The following is a description of a gene set: studied in species Homo sapiens Any process that modulates the frequency, rate or extent of programmed cell death, cell death resulting from activation of endogenous cellular processes. Human Gene Set: GOBP_REGULATION_OF_PROGRAMMED_CELL_DEATH, and this is the list of marker genes: PRAMEF7, PTMA, TAF9B, GAL, APOE, ITGB1, ATF4, MIR22, NONO, MAPK8IP1, SNCB, BCAP31, CBS, USP17L21, CTNNB1, PTK2, SPATA2, MIR142, USP17L17, PANO1, BFAR, ING5, INTS1, RBM10, MTNR1B (NCBI Gene Id 4544), PRAMEF13, CORO1A (coronin 1A), TNFRSF1B, TNFSF11, NCKAP1L, EPC2, PRAMEF26, GLS2, MIR200B, GPX4, RYBP, SON, RPS3A, PPP1CA, TXNIP, BBC3, BBS10, UNG, HSH2D, UFM1, WNT1, TWIST1, AATF, MIR19A, VEGFB, UNC5B, POMC (NCBI Gene Id 5443), CD38, UTP11, DLG5, EYA1, BCL3, PDE1A, CCND2, ITPR1, ANKRD1, ADGRG1, TAF9, UBE2Z, KCNB1, SGK3, NR2E1, CD3G, MAGED1, DBH (dopamine beta-hydroxylase), CDK11A, FAM162A, FAP, MIR29B1, USP17L24, TRAP1, DLC1 (DLC1 Rho GTPase activating protein), BTC, BCL2A1, MTDH (NCBI Gene Id 92140), ERP29, AGO4, SIK1, HTR2A, CAPN10, NPY5R, USP17L18, TMF1, ASAH2, BARHL1, PERP, AURKB, ATP7A, XRCC2, CNTF, ZBTB7A, MAG, UMODL1, MIR204, ITGAV, TERT, SNX6, CAMK2A, TOX3, CASP8, CTTN, MGMT, FOXC2, PLA2G1B, CD2AP, SLC7A11, ICAM1, BCL2, FOXB1, PSMD10, HTATIP2, RASA1, SLC39A7, COPS5, RASSF6, MYCNOS, CASP9, NKX3-2, PEPD, THBS1, MAP3K9, RACK1, TXNDC12, CLIP3, IL2RB, HSPB1, MIR182, KITLG, BCL2L1, VNN1, CBLC, MNT, SNCA, PIK3CG, RPS7, MRGBP, SEMA5A, IL27RA, DOCK8, ERBB4, SARM1, PCSK9, NTF4, AIPL1, CERS6, BCL2L14, PHLDA1, MPV17L, MIR132, CHST11 (NCBI Gene Id 55807), NOP53 (NCBI Gene Id 94457), GNRH1, RIPK1, ID3, ARL6IP5 (NCBI Gene Id 10550), HTRA1, KLF11, NQO1, MIR17HG, RBM5, FBXO7, NR4A2, MECP2, NTRK3, HCK (HCK proto-oncogene, Src family tyrosine kinase), PDCD4, VDAC1, TNFSF9, MIEN1, ARL6IP1, RARG, ANXA1, FAIM, PRKRA, ABL1 (NCBI Gene Id 25), TMEM164, MIR101-1, ZNF622, TARDBP, HGF, IL12A, BRMS1, BNIP3L, EEF1E1, PPIF, APBB2, TJP1, AAMDC, IL12B, IL1A, TNFRSF18, HELLS, RB1CC1, RAF1, MAZ, AQP1, ADPRS, PTMS, NRG1, GATA6, JAK3, NF1 (neurofibromin 1), PLAUR, P4HB (prolyl 4-hydroxylase subunit beta), CASP5, CCAR1, DLX1, NEFL, ATP13A2, ITGB3BP, DPP9, MEAF6, CASP2, APIP, SRPK2, AXL, MMP2, DDRGK1, ARF4, GADD45B, SMG9, PPP2R1B, RICTOR, MBTD1, CCNL1, P2RX7, FHL2, SGK1, SKIL, ORMDL3, CD44, BOK, NOD1, PRAMEF2, F2RL1 (F2R like trypsin receptor 1), APP, MERTK, DHRS2, NTSR1, FGFR2, NUAK2, BMP5, BRD8, RASSF2, CYP1B1, BNIP1, ACTL6A, DDIAS, SET (SET nuclear proto-oncogene), SIN3A, KRAS, SCG2, SERPINB13, MAPKAP1 (NCBI Gene Id 79182, MAPK associated protein 1), PTTG1IP, FCMR, HSPA9, ZSWIM2, TEX261, LOX, E2F1, BTG1, FPR2, WNT4, MIR28, STAT1, ZMYND11, MIR26B, S100A8, PDPN, PHLDA3, GHRL, SOCS2, PLEKHN1, PNMA1, GAS1, CAMK1D, HSPA5, KANK2, NKX2-5, TRAF2, PRF1, RXFP2, AKT1, SLIT2, PELI1, JAK2, CIDEC, SMO, CASP3, PINK1, CSNK2A2, NME1, SH3RF2 (SH3 domain containing ring finger 2), UCN, ITPRIP, ETS1, ARMCX5-GPRASP2, RHBDD1, MIR24-1, RNF183, ITGA1, SAV1, HTRA4, LIG4, TNFRSF25, CAMK2D, PRAMEF27, ANP32E (acidic nuclear phosphoprotein 32 family member E), USP17L1, EYA2, ANGPT1, NOD2, NFKB1, PIK3CD, MDM2, ALX3, PRKCH, GATA2, TNFRSF10C, SLC9A1, TMEM196, CTSD, SLC39A10, PPP1R10, TP53, ENSG00000274276, DAPK1, RAD21, MIR21, MIR181C, KDM2B, LAPTM5, NACC2, CITED2, LATS2, TNFAIP8L1, BTG2, DEDD (death effector domain containing), TGFB3, SELENOS, HIPK3, CIAPIN1, POU4F1, CIDEB, BIRC8, HSPB6, FMR1-AS1, PRKAA1, STK40, SAP18, IL6, TFPT, MIR133A1, PHB1, CREB3L1, WT1, PRAMEF1, CDK1, SPDEF, CRLF1, ANG, PHB2, HIF1A, NME2P1, HRAS, GFRAL, PRAMEF6, ST8SIA2, ATP2A2, BAD, NCK2, DKKL1, USP17L7, SEMA3E, USP17L2, LGALS9, TP73, ANGPTL4 (NCBI Gene Id 93954), ZFP36L1, LEP, PIM1, YWHAZ, VPS72, MAEA, MIR200A, PDK4, GRIK2, GRK5, NRBP2, STAT5B, CARD16, BAG4, GRN, JMY, LAMTOR5, BMP7, CASP4, PRR7, FOXE3, CDKN2A, TP53BP2 (tumor protein p53 binding protein 2), PRDM9 (NCBI Gene Id 56979), ERFE, ASNS, PTCRA, AVEN, CDK11B, SIX4, ACIN1, CCND1, HDAC2, DAB2, PDCD1, HTR2B, GRIN2A, BAG1, IL1B, SYVN1, DAPK2, BCL2L13, IL13, KHDRBS1, FFAR4, IRF5, SLC25A4, ACAA2, PCGEM1, CREB3, OLFM1, CDKN1A, NDUFA13, SIAH1, MAP2K5, BIN1, FOXA1, DNM2, UBQLN1, ING1, ATAD3A, NANOS3, HSPG2, MIR222, NKX3-1 (NCBI Gene Id 4824), PROC, MAPK8, ISL1, STXBP1, HERPUD1, MICAL1, PRKD2, PLA2G3, BCL2L10, FNIP1, MTCH2, TMBIM1, SPHK2, CALR, FGB, RPL26, TMIGD1, EPO, USP42, MED1, RBCK1, FZD1, DYRK3, SIRT2, TM7SF3, CDSN, TNFRSF12A, PYCR1, CD274, MDK, PTGIS, ANP32CP, USP15, ZFP36, TP53BP1, NCOA1, CASP12, RPS6KA1, AIFM1, FOXP1, MIR214, TBX20, PLAGL2, MAGEA3, XBP1, HNF1B, TFAP2A, BMPR1B, RNF122, MIR30B, GRAMD4, USP17L3, FOXO1, ATOH1, TMEM161A, FZD3, TLR4, MYO18A, RGL2, CD28, ZNF830 (NCBI Gene Id 91603), PKHD1, TNFRSF6B, EYA3, ALK, ERCC5, PAX8, PDX1, CDK5, IFNB1, BECN1, HSP90AA1, TSPO, TRIM39 (tripartite motif containing 39, NCBI Gene Id 56658), DLL1, MDM4 (MDM4 regulator of p53), RHOA, RIPK2, PDPK1, TNFRSF1A, ANP32B, BIRC6, EMILIN2, TNFAIP8L2, USP36, CCN1, FBXW7, DDAH2, USP17L5, QRICH1, HTT, POR, STIL, FGF10, PRAMEF22 (PRAME family member 22), SFRP1, EMILIN1, BTK, TLE5 (NCBI Gene Id 166), HIP1R, SC5D, PLCG2, RAPGEF2, TEX11, BIRC2, CXCL12, DEDD2, PAK4, FGFR1, RAD9A, TRIM2, SLC40A1, SRSF6, CASP7, YME1L1, PTH, SLC25A1, TMBIM6, ANXA4, PDCD6, PRDX2, RFFL, SGMS1, BCL10, TNF, KCNMA1, TNFSF12, FBH1, HCLS1 (NCBI Gene Id 3059), PTGS2, PRAMEF4, PRAME, UBB, MAEL, ADAR, EN2, SRPX, PIM2, NFATC4, EDN1, IGF2R, DNAJA3, TBX3, ADORA1, PIK3R1, LRP8, IKBKG, SOX8, FTH1, KRT18, FLNA, INHBA, SH3RF1, ADIPOQ, AKT1S1, FRZB, KIT, KAT2B, CARD6, BLID, ZC3H8, HIPK2, EGLN2, MAPK8IP2, BCL2L11, NPPC, ZNF304, FGF2 (NCBI Gene Id 2247), PLK5, AKR1A1, STK26, BCLAF1, HSPB2, IGF1R, HSP90B1, CRYAB, SLC25A5, USP17L11, NNT, PRAMEF20, HDAC3, KNG1, PPEF2, CAST, CEBPB, PAK5, PA2G4, GSDME, PYCARD, MIR103A1, SHH, DUSP6, MYC, KHDC3L, GBE1, MIR15B, RPL10, KPNA1, TIGAR, MIR495, BIRC7, CD74, SLC25A6, CXCL10, NSMF, BABAM2, NTRK1, INHBB, ADCY10, PRELID1, MARCHF7, RAG1, RORC, STK17A, TRRAP, SLC46A2, BID, NAE1, FASLG, ATAD5, KIF14, GBA1, AZU1, UBD, UNC5C, TFAP4, STPG1, TFRC, AKR1C3, KAT5, ACTC1, SERPINB2, PDIA3, STK3, NOS1, IVNS1ABP, UCP2, USP17L20, GPAM, GIMAP8, CBL, XIAP (X-linked inhibitor of apoptosis), MPO, ERBB2, HMGA2, TREM2, HOXA13, DAB2IP, MIR34A, CAPN2, RRM2B, MIR375, SCRT2, RARB, API5 (apoptosis inhibitor 5), SFRP4, YAP1, SNAI1, EEF2K, SLC25A27, ARAF, TRIM24, S100B, PPP2R1A, PDCD5, TIA1, PLXND1 (NCBI Gene Id 23652), SLC25A31, MCL1, NOTCH2, CASP14, MAGEA4 (NCBI Gene Id 4103), TSC22D3, PITX3, STK4, BEX2, CARD10, RUVBL2, OXR1, STUB1, SQSTM1, WNT7A, RNF144B, ATG5, FGF20, DCUN1D3, MIR30E, CCL5, NGF, USP17L6P, ZBTB16, COL2A1, PARK7, MIR186, CLCF1, CEACAM5, TSC22D1, PF4, BDKRB2, TYRO3, MAP3K11, PRAMEF8, CTNNBL1, DDR2, DEPTOR, NRP1, FXN, WNT10B, FYN, EP400, IDO1, TOMM70, ENO1, MIR4516, RTKN, BAX, MSX2, PLCG1, GDF5, ITM2C, POU3F4, WNT16, RRN3 (RRN3 homolog, RNA polymerase I transcription factor), TSLP, TRAF5, EIF2AK2, CDK19, IP6K2, NOS3, FRS2, YBX3, VEGFA, ACSL5, CAT, CRADD, PRLR, SIRT4, ACER2, ARMC10, GLI3, CARD8, PDCD2, LPAR1, CDKN2D, EIF2AK3, UNC13B, TPT1, PIM3, CD248, CCR7, TMBIM4, EVI2B, HDAC1, WNT5A, MIR451A, COMP, GATA4, XPNPEP1, MIR125A, FAS, AHI1, ECT2, GLO1, TRAF7, MAP3K5, MIR98, PCGF2, ADAM8, TENT5B, GHSR, BAG3, EPC1, DIPK2A, LILRB1, PSMG2, NAA35, PRAMEF5, GDNF, CALHM2, MAP3K20, CLU, USP17L19, CLEC5A, ATF5, GCG, MET, BACE1, BARD1, NUP62, ARHGEF2, GPX1, DUSP1, ACVR1, ANP32A, RNPS1, CASP1, LMNA, STYXL1, LCN2 (NCBI Gene Id 3934), ACER3, NAA38, BMF, DRAXIN, URI1, FADD, PRODH, ATM, REST, LIMS2, BDNF, MIR27B, HSPD1, SOCS3, RNF31, CTSH, YEATS4, MIR212, DNAJC3, FATE1, PTPA, RETREG1, PTRH2, MAP3K10, WNK3, CCNL2, BCL2L2, CEACAM6 (CEA cell adhesion molecule 6), LGALS3 (NCBI Gene Id 81625), GHITM, LATS1, TGFB1, TNIP2, ITGB3, PPT1, SLK, ARHGEF7, SERINC3, FOXL2, ALPK2, EEF1A2, LYN, TXNDC5, DNAJC5, ADNP, ACLY, BCL2L15, ELL3, KDM1A, NEUROD1, GRID2 (NCBI Gene Id 2895), CSRNP3, PAK2, TRAF6, PPID, EI24, PELI3, FCER1G, IL31RA, NACA, MIR361, MARK4, HMOX1, TRADD, ASAH1, CX3CR1, NFE2L2, PAX7, CCL2, C1QBP, SPRY2, BAG5, PPARG, NAIP, HIGD2A, SMAD3, BIRC3, LRP2, SLC1A1 (solute carrier family 1 member 1), TFAP2B, HMGN5, ACTN3, MIR29A, USP17L13, KDR, TNFRSF10D, FKBP8, AMIGO2, MIR195, ANGPT4, ADA (adenosine deaminase), LTK, GPRASP3, RAPSN, FBXO11, JUN (Jun proto-oncogene, AP-1 transcription factor subunit), PRKCQ (protein kinase C theta), GRINA (glutamate ionotropic receptor NMDA type subunit associated protein 1), IFIT2, NPM1, MSX1, DAXX, PPARGC1A, CD40, ITGA4, TBX1, CFDP1, CHD8, SMAD6, CCR5, PIDD1, HIP1, MOAP1, IRS2, ALOX12, APC, PIK3R3, AR, LRP6, CRYBA1, TFAP2D, SLC7A5, AGT, APAF1, PRAMEF25, PTPN2, ZDHHC17, USP17L4, PRR5, ABCC9, CSF1R, PRKN, TNFSF10, BAG6, NLRP1, GCLC, CAPN3, ATF3, HAND2, CD27, IAPP, NDNF, DKK1, SEPTIN4, CASP10 (NCBI Gene Id 843), GATA1, TMEM14A (transmembrane protein 14A), GRM4, ZBP1, IGFBP3, RUVBL1, ST3GAL1, ARG2, PRAMEF17, CD40LG, HMGB1, USP17L10 (NCBI Gene Id 100287144), G0S2, BCL2L12 (BCL2 like 12), MAP2K1, MIR675, EGR1, GCLM, CX3CL1, CNTFR, MIR590, SCIN, IRF8, PLK3, KRIT1, ADAMTS20, STAMBP, MIR17, TMEM109, ITGA5, RSL1D1, WNT11, IFI6, FAIM2, FIGNL1, DSTYK (dual serine/threonine and tyrosine protein kinase), SIRT5, MIR138-1, NET1, IRF3, BMP4, NAT8B, RPS6, APOH, HSPA1A, WWOX, ZNF16, PRAMEF18, RET, MYBBP1A, MUTYH, TOP2A, C3orf38, DPP8, CBX4, ARG1, EGR3, NCK1, GSTP1, AKR1B1, PEA15, G6PD, DFFA, IFNG, NTRK2, TRIAP1, DSG2, KATNB1, RRP1B, SOX4, CLN3, ARHGDIA, HEY2, CREB1, RARA (NCBI Gene Id 5914), ARNT2, MAP3K12, ING2, GPI, SYCP2 (NCBI Gene Id 10388), TGFB2, MTOR, TRIM32, GSN, ALDH1A3, IL6ST, PTPRZ1, EIF2B5, MIR27A, ACTN2, PHIP, IFT57, CCL3, CDKN1B, MIR1-1, CTLA4, DDX3X, PIP, ITGA6, TMEM215, RGCC, PALB2, USP47, RB1, SLC35F6, PRAMEF12, MIRLET7F1, ACTN1, GADD45G, IRF7, PIK3CA, MIR19B1, PTPMT1, CRIPTO, HRK, CIDEA, PCDHGC5, LONRF2, HYOU1, CLN8, RPS6KA3 (ribosomal protein S6 kinase A3), PLAC8, EPHA4, HPGD, SFRP2, IL7R, PRAMEF33, TNFRSF8 (TNF receptor superfamily member 8), LHX4, NAA15, TNFSF18, MADD, SIAH2, LRP5, RPS3, LGALS16, ADORA2A, CSNK2A1, POU3F3, MAL (NCBI Gene Id 4118), ATF6, AGAP2, OPN3, CARD11, SOD2, QARS1, BCL6, AMBRA1, MIR210, DAPK3, MYOCD, HOXA5, CARM1, CITED1, ZNF268, AGTR2, OSR1, ESR1, NOTCH1, GSK3B, MYDGF, TPD52L1 (NCBI Gene Id 7164), MORF4L1, RNF34, MIR320A, ITPKB, PCDHGC3, ERBB3, CASP6, DDX20, RPS6KB1, NR3C1, MIR16-1, NKX2-6, C8orf44-SGK3, CD3E, ITCH, CXCR2, MAP2K4, PRNP, CDH5 (NCBI Gene Id 1003), AVP, PPARD, NOX1, STAT5A, SOD1, TNFRSF10B, PIAS4, RNF157, GNAI2, ING3, TNFSF14, PNMA5 (NCBI Gene Id 114824), AARS1, PIK3CB, IGF1, MALT1, MIR107, HPN, ALKBH1, ASCL1, LCK, MMP9, CARD17P, DAD1 (NCBI Gene Id 1603), NHERF1, HSF1, PTPN6, PRAMEF19, MLLT11, PRAMEF14, FMN2, TNFRSF10A, KIFAP3, POU4F2, NME5, SOX9, MNAT1, VSTM2L, SOX10, EGFR, PRKDC, INCA1, TLR3, NR1H4, MIRLET7B, DDIT3, TEK, HS1BP3, DDX42, BAK1, OPA1, MIR106B, NUGGC, DNAJA1, MIR140, ZC3H12A, TP63, PHLPP1, SERPINB9, PRDX5, BCL11B, HTRA2, BIK, F2R, BRCA1 (BRCA1 DNA repair associated), NF2, PPP1R13B, GPER1, IFIT3, TRIM35, NME2, INS, MAPK7, IL7, THRA, LTB, E2F3, ECSCR, CYLD, CERKL, FGF8, CDK5R1, HYAL2, OGT, PRAMEF15, MIR137, HCAR2, NOL3 (nucleolar protein 3), ZFAND6, AKAP12, NOG, TNFAIP3, ERCC3, MAP2K7 (mitogen-activated protein kinase kinase 7), SFPQ, RHOB, CCL21, MT3, SERPINE1, SYNGAP1, TNFAIP8L3, VCP, UBE2B (NCBI Gene Id 7320), IL20RA, CARD18, DMAP1, SMAD5, GPLD1, FCAR, FGF4, SPTLC1, MAPK8IP3, FIS1, VTCN1, ARHGAP10, PAWR, RAMP2, F3 (coagulation factor III), AIMP2, RIPK3, FAF1, LTBR, LYPD3 (LY6/PLAUR domain containing 3), SIX1, TAX1BP1, NR4A3, TNFSF15, AREL1, SRC (SRC proto-oncogene, non-receptor tyrosine kinase), PARL, BMPR1A, WFS1, APEX1, SIRT1, CRYAA, PAGE4, CAAP1, CARD9, FGA, MELK, HNRNPK, LTA, IER3IP1, MIR449A, VDR, PRKCZ, FZD9, ID1, MIR223 (microRNA 223), LGALS2, NEURL1, FANK1, FSTL1, MTCH1, ACKR3, ADAM17 (ADAM metallopeptidase domain 17), OMA1, IL19, CFLAR, SYCE3, ZEB2, PHLDA2, IL10, INPP5D, C8orf17, PLK1 (NCBI Gene Id 5347), EN1, NOC2L, NGFR, RBM25, PARP1 (poly(ADP-ribose) polymerase 1), MAP4K4, LRRK2, SOX2, RELA, MIR29C, MITF, NTF3, HRG, MIR485, ANXA5, PSME3 (proteasome activator subunit 3), PRDM11, PCDHGC4, USP17L15, CXCR3, PDE3A, GADD45A (NCBI Gene Id 1647), PIAS1, ATG7, FOXO3 (NCBI Gene Id 2309), MYCN, PRAMEF10, PROP1, VHL, CPEB4, PNMA3, USP17L12, CSF2, CTNNA1, ACTN4, PRMT2, FEM1B, DHCR7, B4GALT1, FCGR2B, EPHA7, SLC27A4, CIB1, TRAF3, ATOX1, PAX2, LHX3, PROK2, NMNAT1, CCL19, LGALS1, PPIA, TIFAB, IER3, PLSCR3, TOPORS, TIMP1, CHL1, CTH, MLST8, PRKCI, DDX19A, IL11, PNMA2, DIABLO, MIR15A, NUPR1, PDCD10, FGG, HLA-G, NAA16, EIF5A, SUPV3L1, PIP5KL1, NR4A1, NIBAN2, ALDH1A2, LCMT1, EGLN1, PRKCA, HMGB2, TAF6, MORF4L2, LEF1, PRAP1, MYB, SKP2 (NCBI Gene Id 86997), PSMC5, ACTB, PLA2R1, NES, SCX, AIFM2, SYCP2L, ASIC2, IKZF3, USP27X, FLT3, PTPRC, SIGMAR1, PMAIP1, SP1, RPS6KA2, BMI1, PTGFR, AURKA (NCBI Gene Id 8465), PLK2, PML, MIR181B1, GSK3A, RTN4, HSP90AB1, STK17B, TCF7L2, LTF, FUT1, BNIP2, NLRP2B, FOXC1, MECOM, IL4, PRKCD, EDNRB, ING4, SCRIB, ROCK1, EYA4, BIRC5, SHC1, BNIP3, SNAI2, FLT4, MIR92A1, VPS54, MFN2 (NCBI Gene Id 9927), CHEK2, MIF, PRAMEF9, ANKLE2, MIR20A, MIR23A, MIR221, HAX1, HSPA1B, LACRT, S100A9, CARD14, FLCN, NLRC4, GATA3 (GATA binding protein 3), TLE1, DYNAP, CCAR2, MNDA, MUC1, DDB1, TRAF1, MIR145, TCIM, GRIA4, TGM2 (transglutaminase 2), CTSB, LGMN, KLF4, BMP2, THAP11, SPHK1, ADAMTSL4, ENG, GZMA, CAV1, USP17L8, IL2, MIR126, PTK2B, RTKN2, TCTN3, SMAD4, EIF2S1, HYPK, KLHL20, CDC73, PRKAA2 (NCBI Gene Id 5563), MEF2C, TLR6, CD160, TP53INP1, TRAF4, BCAR1, CTSC, BRAF, DNMT1 (DNA methyltransferase 1), MRE11, GOLPH3, STRADB, ANKRD13C, PTPN1, GREM1, USP17L22 (NCBI Gene Id 100287513), PPARA (peroxisome proliferator activated receptor alpha), FBXO10, EGLN3, PRKCG, MAPK9, PSEN1, SMPD1, NPC1, TMC8, IHH, ZNF385A, STX4, PRDX3, EFNA1, SDF2L1, MSH2, CFL1, ALX4, SEMA4D, GAS6, TGFBR1, TNFAIP8, ACVR1C, APBB1, SP100, MFSD8, ENDOG, MIR199A1, PRAMEF11, ANO6 (anoctamin 6), MIR146A, HIGD1A, PPP5C, ZPR1